Given this list of marker genes GBA1, IGF1, CEPT1, JPT1, PURB, MAP1LC3A, FAR1, PTGIR, DHPS, RAP2A, PRAM1, RRAD, COMMD6, SAP30, TFEB, SMC5, RNF217, DYNC1H1, SLFN13, PHKG2, CDK9, RPL13, ASH1L, ITPK1, MYO9B, IFI35, ISCU, RPL38, MAPKAPK2, RELCH, CWC15, VPS13B, PRDM2, DSTYK, PKM (pyruvate kinase M1/2), TMEM50B, SIPA1, RNPEPL1, PSAP, DDRGK1, RCHY1, CCDC88B, TM6SF1, SLC66A3, HDAC5, ARL4D, ABRACL, OTULIN (NCBI Gene Id 90268), IK, NAB2, SSU72, STAT1, SNX13 (NCBI Gene Id 23161), MARK3, BMPR2, TMEM86A, ARHGAP25, HES1, EZH1, GAS7, PAGR1, CD300LF, ASB13, DZANK1, ATXN1L, TRAPPC8, ABCA7, ITK, CAMK2B, RNPEP (arginyl aminopeptidase), PTPN12, TNRC6A, TMEM185A, NSD3, ENTPD7, RTN1, ITPR3, FHIP2B (NCBI Gene Id 64760), RCBTB2, STIMATE (STIM activating enhancer), NDUFA1, TAX1BP3, MAF1, SORT1, EMC2, TMCC3, ITPRIPL2, STARD5, MKKS, IRAG2, PPCDC, CD22, GIT2, DGKG, PLEKHG2, XPA, KBTBD7, GRAP2, ZC3H7A, NOSTRIN, SBNO1, CMKLR1, SMAD7, PTTG1IP, RPL37A, TBC1D9, AIP, CHD3, TACC1, PFDN5, GALNT9, CFB, AGFG1, CTBS, PGGHG, IKZF1, SP1, ATP6V1F, INHBA, TRIM8, LRRK2, YIPF3, CNIH2, HPS5, TGFB3, SMDT1, SNX1, DHRS1, CSNK1E, MYO5A, CD177, RABEP2, CD247, CLOCK, USF2, CTDSP1, KCNJ8, CLCN4, NHERF1, TM9SF4, RWDD2A, GPR68, BIN3, CNOT4, RGS14, PBX3, ACTG1, ATP6V0B, ERO1B, DUBR, ATP1B1, ATF2, CCDC88A, SUSD6, VAMP4, CHKB, ZDHHC9, ICAM1, CXCL14, GSK3A, MFAP1, GGNBP2, ARHGEF2, ACVR2A, ATOSA, KCNK6 (NCBI Gene Id 9424), FAU, TNFAIP8L2, USP12, HIGD2A, FAM219B, MIA2, ITGA2, PPP3CC, HAPSTR1, PARP9, LENG9, RABAC1, JAK1, NAAA, RIC8A, PCBD2, RAF1, PDCD6IP, CDC40, TRIM39, PIGF, COX14, LYL1, PCMTD1, PPP1R21, OTUD5, ETS1, SBK1, MTHFR (NCBI Gene Id 4524), QPCT, B3GAT3, DNAJC17, ZNF281, ATOX1, here is a description of the gene set: species: Homo sapiens from publication Konuma T, Nakamura S, Miyagi S, Negishi M, Chiba T, Oguro H, Yuan J, Mochizuki-Kashio M, Ichikawa H, Miyoshi H, Vidal M, Iwama A (PMID 21540074) Human Gene Set: GSE27786_LIN_NEG_VS_NKCELL_DN Genes down-regulated in comparison of lineage negative versus NK cells. Each fraction of mouse hematopoietic cells was purified by cell sorting from bone marrow of 8-week-old C57BL/6 mice, and its gene expression was analyzed.